Given this list of marker genes IL4R, MUSK, AXL, EPHB1, ERBB2, NRP1, EPHA4, FGFR1, FGFR3, IL3RA, PDGFRB, LEPR (NCBI Gene Id 3953), KIT, IL13RA1, CSF2RA, CSF2RB, IL10RA, F3, EPHA2, DDR2, PTK7, TEK, IFNGR1, MYLK, PDK4, CDKN1A, GRK1, PDGFRA, ROR1, PDGFRL, EFNA4, IL2RB, TIE1, CCL2, DAPK1, IL7R, EPHB6, MST1R, EFNB3, IL2RG, EPHB2, GRK5, MERTK, FGFR2, CDK5R1, CSF3R, here is a description of the gene set: RTK signaling. species: Homo sapiens Human Gene Set: MODULE_259